The following is a description of a gene set: Mouse Gene Set: GOBP_VACUOLE_ORGANIZATION A process that is carried out at the cellular level which results in the assembly, arrangement of constituent parts, or disassembly of a vacuole. species: Mus musculus, and this is the list of marker genes: Ephb2, Vps33a, Wipi2, F830016B08Rik, Tmem41b, Rab3gap2, Mtmr3, Gnptab (N-acetylglucosamine-1-phosphate transferase, alpha and beta subunits), Ppp3cb, Tpcn2 (NCBI Gene Id 233979), Tmem39a, Ctsd, Fez2, Atg12, Lamp1, Lrrk2, Atg4d, Atg5, Chmp1a (charged multivesicular body protein 1A), Ifi47, Pik3c3, Trp53inp1, Atg101, Tmem9, Lyset, Ccdc115, Vps18, Mbtps1, Rab43, Fez1, Hook2, Ift88, Mfsd8, Atp2a2, Chmp5, Cln5, Nsfl1c, Tmem165, Vps35, Rab7b, Vps54, Chmp4b, Creg1, Sec22b, Cln6, Map1lc3b, Arf1, Wipi1, Atg4a-ps, Zfyve26, Map1lc3a, Fhip1b, Tgtp1, Gm12185, Laptm4b, Vps4b, Stx12, Atg2a, Rab7, Smcr8, Chmp4c, Atf2, Ralb, Trp53inp2, Pip4k2a, Rb1cc1, Traf6, Ift20, Grn, Pi4kb, Emc6, Ubxn2b, Spns1, Hps1, Rab33a, Chmp7, Syt7, Arsg, Elavl1, Cln3, Pip4k2b, Naglu, Npr2, Atp10b, Chmp3, Tasl, Snx30, Vmp1, Lrsam1, Lyst, Dnajc16, Hps4, Wdr45b, Pip4k2c, Rab1a (RAB1A, member RAS oncogene family), Cln8, Atg9a, P2rx7, Anxa2, Pikfyve, Rab19, Atg16l2, Atp6ap2, Flcn, Atg9b, Abca1, Chmp1b, Sting1, Aktip (NCBI Gene Id 14339), Lamp2, Ubxn2a, Coro1a, Pik3c2b, C9orf72, Nupr1, Mfn2, Rab23, Atg13, Atg16l1, Arfip2, Atp13a2, Becn2, Ppt1, Fig4, Ulk2, Gabarapl1, Slc45a2, Atg3, Scfd1, Synpo2, Mtm1, Atg7, Tfe3, Tom1, Wdr45, Atg4b, Gm5431, Pik3c2a, Psen1, Efnb1, Lipa, Mcoln1, Snx7, Myo7a, Clvs2, Becn1, Fsip1, Fnip1, Atg10, Tmem199, B4galnt1, Atg4a, Ubqln1, Smurf1 (SMAD specific E3 ubiquitin protein ligase 1), Chmp1b2, Arl8b, Lamtor1 (NCBI Gene Id 66508), Ubqln2, Snx4, Irgm2, Lrba, Tmem106b, Tmem175, Mtor, Ulk3, Ext1, Gba1, Iigp1, Rnf5, Gm12250, Srpx, Igtp, Phf23, Washc5, Gaa, Man2a1, Trex1, Tgtp2, Atg2b (autophagy related 2B), Tcirg1, Rab1b (NCBI Gene Id 76308), Gm4841, Trim32, Pla2g5, Tfeb, Ap3b1, Clvs1, Spg11, Laptm5, Rufy4, Stx17, Epm2a, Hexb, Rab39, 9930111J21Rik1, Rab14, Pacs2, Atg14, Chmp2b, Rab33b, Tpp1, Idua, Vps16, Snapin, Hook3, Hook1, Sh3glb1, Hexa, Iigp1c, Chmp6, Ehmt2, Tbc1d12, Ulk1, Ap4m1, Moap1, Rab3gap1, Ap5z1, Snx18, Hspa8 (heat shock protein 8), Gabarapl2, Acp2, Rab20, Stbd1, Oca2, Rnf186, Hsd17b1, Hid1, Atp6v0c, Pink1, Zkscan3, Irgq, Vps11, Gabarap, Chmp2a, Elapor1, Vps4a, Rab34, Atg4c, Chek2, Tbc1d14, Ambra1, Irgm1